Given this list of marker genes ZBTB7A, XRCC6, XRCC5, PRKDC, UVRAG, here is a description of the gene set: Human Gene Set: GOCC_DNA_DEPENDENT_PROTEIN_KINASE_COMPLEX A protein complex that is involved in the repair of DNA double-strand breaks and, in mammals, V(D)J recombination events. It consists of the DNA-dependent protein kinase catalytic subunit (DNA-PKcs) and the DNA end-binding heterodimer Ku. species: Homo sapiens